Given this list of marker genes RPA4, RPA1, MCM7, GMNN, POLA1, CDC45, CDC6, MCM4, DBF4, POLE, ORC3, CDC7, MCM10, ORC6, CDK2, MCM2, PRIM2, ORC5, POLE2, MCM8, RPA2, MCM5, POLA2, ORC2, MCM3, POLE4, POLE3, CDT1, RPA3, ORC1, ORC4, PRIM1 (NCBI Gene Id 5557), MCM6, here is a description of the gene set: Activation of the pre-replicative complex studied in species Homo sapiens Human Gene Set: REACTOME_ACTIVATION_OF_THE_PRE_REPLICATIVE_COMPLEX